The following is a description of a gene set: part of: Rab regulation of trafficking species: Homo sapiens Reactome Pathway: TBC/RABGAPs Rab GTPases are peripheral membrane proteins involved in membrane trafficking. Often through their indirect interactions with coat components, motors, tethering factors and SNAREs, the Rab GTPases serve as multifaceted organizers of almost all membrane trafficking processes in eukaryotic cells. To perform these diverse processes, Rab GTPases interconvert between an active GTP-bound form and an inactive, GDP-bound form. The GTP-bound activated form mediates membrane transport through specific interaction with multiple effector molecules (Zerial & McBride 2001, Stenmark 2009, Zhen & Stenmark 2015, Cherfils & Zeghouf 2013). Conversion from the GTP- to the GDP-bound form occurs through GTP hydrolysis, which is not only driven by the intrinsic GTPase activity of the Rab protein but is also catalysed by GTPase-activating proteins (GAPs). GAPs not only increase the rate of GTP hydrolysis, but they are also involved in the inactivation of RABs, making sure they are inactivated at the correct membrane. Human cells contain as many as 70 Rabs and at least 51 putative Rab GAPs. Only a few of these GAPs have been matched to a specific Rab substrate. The Tre-2/Bub2/Cdc16 (TBC) domain-containing RAB-specific GAPs (TBC/RABGAPs) are a key family of RAB regulators, where the TBC domain facilitates the inactivation of RABs by facilitating activation of GTPase activity of the RAB. Studies suggest that TBC/RABGAPs are more than just negative regulators of RABs and can integrate signalling between RABs and other small GTPases, thereby regulating numerous cellular processes like intracellular trafficking., and this is the list of marker genes: POLG, TBC1D25, RAB33A, RAB7A, SYTL1, RABGAP1, RAB4A, RAB8A (RAB8A, member RAS oncogene family), TSC2, TBC1D3, TBC1D20, RABGEF1, RAB5B, TSC1, TBC1D16, RAB5A, TBC1D24, TBC1D17, ULK1, OPTN, TBC1D2, TBC1D15, GABARAP, TBC1D7, RABEP1, RAB11B, ARF6, RAB33B, RAB11A, MAP1LC3B, RAB6A, GGA1, RAB5C, RAB6B, RAB8B, GGA2, TBC1D14, RAB7B, GGA3, TBC1D10A, TBC1D10C, TBC1D10B, RAB35, GABARAPL2, TBC1D13